The following is a description of a gene set: An anomaly of the pineal gland,a small endocrine gland in the brain that produces melatonin. Human Gene Set: HP_ABNORMALITY_OF_THE_PINEAL_GLAND species: Homo sapiens Abnormality of the pineal gland, and this is the list of marker genes: KANSL1, FLII, DEAF1, RAI1, WDR26, INSR, KRAS, PSMD12, RNU4-2, VAX1, NR1H4, ADNP, NONO, PRNP, ABCB11, PNPLA2, ABCB4, IQSEC2, DKC1, BPTF, GALNT2, ATP8B1